The following is a description of a gene set: Any process that stops, prevents, or reduces the frequency, rate or extent of B cell differentiation. species: Homo sapiens Human Gene Set: GOBP_NEGATIVE_REGULATION_OF_B_CELL_DIFFERENTIATION, and this is the list of marker genes: SFRP1, HMGB3, ID2, INHBA, INHA, BCL6, CR1